The following is a description of a gene set: Simple febrile seizure A short generalized seizure, of a duration of <15 min, not recurring within 24 h, occurring during a febrile episode not caused by an acute disease of the nervous system intracranial infection or severe metabolic disturbance. species: Homo sapiens Human Gene Set: HP_SIMPLE_FEBRILE_SEIZURE, and this is the list of marker genes: KCNQ3, AASS, PRRT2, SYNGAP1, TSEN54, DEPDC5, TSEN34, TBC1D24, SCN3A, CHD2, TSEN15, KCNQ2, BCKDK, SCN8A, TSEN2 (NCBI Gene Id 80756), SEPSECS, NPRL2, SCN2A, NPRL3, NEXMIF, SCN1A, SLC6A1, WAC, SLC2A1, AP2M1, DYRK1A, CPLX1, PSMB9